The following is a description of a gene set: The chemical reactions and pathways resulting in the formation of UTP, uridine (5'-)triphosphate. studied in species Homo sapiens Human Gene Set: GOBP_UTP_BIOSYNTHETIC_PROCESS, and this is the list of marker genes: NME3, NME9, CAD, NME2P1, NME5, NME1, NME2 (NME/NM23 nucleoside diphosphate kinase 2), NME7, NME4, NME6